The following is a description of a gene set: species: Mus musculus This event has been computationally inferred from an event that has been demonstrated in another species.<p>The inference is based on the homology mapping from PANTHER. Briefly, reactions for which all involved PhysicalEntities (in input, output and catalyst) have a mapped orthologue/paralogue (for complexes at least 75% of components must have a mapping) are inferred to the other species. part of: Adaptive Immune System electronically inferred by orthology from the curated human pathway Reactome Pathway: Rap1 signalling, and this is the list of marker genes: Rasgrp1, Prkaca (protein kinase, cAMP dependent, catalytic, alpha), Prkacb